Given this list of marker genes TP63, TM2D3, YJEFN3, MFNG, CBFA2T2, BMP7, DLL3, NEURL1, TSPAN14, RITA1, ASCL1, CCNC, JAG2, GATA2, ADAM10, DLK2, LLGL1, GSX2, STAT3, AAK1, HES5, GAS2, ROBO1, POGLUT1, SRC, NOD2, DLX1, NOTCH1, ARRB1, BCL6, PDCD10 (NCBI Gene Id 9226), PRAG1, TSPEAR, CHAC1, EPN2, TCIM, HEY1, NOTCH2NLB, CNTN6, NOS3, NOTCH2NLC, ROBO2, YAP1, EGFL7, LRRK2, MIR126, ACVRL1, DLK1, TSPAN15, LFNG, BMP2K, ARRDC1, BEND6, MESP1, NOTCH2NLA, KIT, SLC35C1, JAG1, SYNJ2BP, DTX1, NEPRO, POFUT1, FGF10, FBXW7, SLC35C2, MIR212, GATA5, MIR200C, HEY2, NLE1, HES1, YTHDF2, GALNT11, TSPAN5, MIR141, POSTN, CDK3, PRKCI, DLX2, RFNG, MIR1224, HIF1AN, NFKBIA, WNT1, CD46, SREBF2, ENHO, OVOL2, GDF2, ZBTB7A (zinc finger and BTB domain containing 7A), TGFB2, IL6ST, DLL1, MMP14, MAGEA1, HERC2, ITGB1BP1, DLL4, ZMIZ1, LLGL2, WWP2, METTL3, CCN3, AKT1, NRARP, here is a description of the gene set: Any process that modulates the frequency, rate or extent of the Notch signaling pathway. Human Gene Set: GOBP_REGULATION_OF_NOTCH_SIGNALING_PATHWAY species: Homo sapiens